Given this list of marker genes Ptk2b, Cxcl13, Xcl1, Hsd3b7, Il4, Cyp7b1, Ch25h, BC037156, Gas6, here is a description of the gene set: The directed movement of a B cell guided by a specific chemical concentration gradient. Movement may be towards a higher concentration (positive chemotaxis) or towards a lower concentration (negative chemotaxis). Mouse Gene Set: GOBP_B_CELL_CHEMOTAXIS species: Mus musculus